Given this list of marker genes PPP2CA, HSPA1A, PJA2, OASL, PUM2, TAB1, MARK4, ANKRD17 (NCBI Gene Id 84177), MAVS, FLOT1, TLR9 (toll like receptor 9), HDAC6, KCNK6, TLR6, PRKD1, BTK, ZDHHC1, MARCHF5, LRCH4, TIRAP, HSP90B1, GBP2, P2RX7, ZDHHC5, TRIM3, DHX33, ZNRF1, TLR4, RTN4, LBP, NINJ1, PLCG2 (phospholipase C gamma 2), HSPA1B, CD14, MAP3K7, USP15, F2RL1, SLC19A1, MYD88, NR1H3, TICAM2, TREML4, LATS1, WDFY1, HMGB1, LTF (NCBI Gene Id 4057, lactotransferrin), SLC15A4, SLC46A2, ZC3HAV1, LATS2, ZCCHC3, NEK7, USP17L2, MFHAS1, CYBA, GBP5, IFI35, RSAD2, DDX3X (DEAD-box helicase 3 X-linked, NCBI Gene Id 730543), TRIM15, ZDHHC3, NAGK, GDI1, USP50, STMP1, SLC15A3, DHX58, PTPN22, DDX60, MAPK8, ATAT1, ZDHHC9, TLR1, PUM1, CAV1, RNF39, PELI1, CCDC134, TASL, CD36, BRCC3, here is a description of the gene set: Human Gene Set: GOBP_POSITIVE_REGULATION_OF_PATTERN_RECOGNITION_RECEPTOR_SIGNALING_PATHWAY Any process that decreases the rate, frequency or extent of a pattern recognition receptor signaling pathway. species: Homo sapiens